Given this list of marker genes PLA2G4C, FASN, FAR1, DHRS7B, SELENOI, PEX7 (peroxisomal biogenesis factor 7), PXMP4, EPHX3, PEDS1, PLA2G4A, LIPE, PLA2G6, PLA2G7, EPHX2, PLAAT3, CHPT1, AGPS, PAFAH1B1, ALOX12, NCEH1, LPCAT2, ALOX5, GNPAT, PLA2G10, EPHX1, AGMO, TMEM86B, here is a description of the gene set: Human Gene Set: GOBP_ETHER_METABOLIC_PROCESS The chemical reactions and pathways involving organic ethers, any anhydride of the general formula R1-O-R2, formed between two identical or nonidentical organic hydroxy compounds. species: Homo sapiens